Given this list of marker genes WARS1, POP7, PLK4, RNF150, RHOC, PLB1, ZNF618, PLP1, SAGE1, PXDNL, SRL, RHBDF2, PLD1, PRKX, WDR33, RAB9A, SUMO4, CARD19, PSMG2, RUSC1, GFUS, SEPHS2, STARD3, YAP1, PSMA6, SSB, RHOU, RENBP, TTTY13, ZNRF2, SEC61B, PNN, PIGV, PLIN4, TINF2, TIMP1, ROCK1, TRIM36, SLC4A9, TOP1, PLEKHJ1, SNAI3, PSRC1, TRIP6, SLC35F3, SLFNL1, SCARF2, TP53INP2, TNFSF12, SPATC1, PRKAR2B, TINCR, TRIP12, PKN3 (protein kinase N3), TDRD7, SMAD1, UGT2B17, SLC25A3, RPL26L1, SNAP91, TMEM158, TRIM16, SPACA7, THBD, TTC33, PLA2G2A, SMC1A, SCNN1G, SYT14, WDHD1, PSKH2, SOX2-OT, S1PR2 (sphingosine-1-phosphate receptor 2), TRAPPC6B, SLC16A4, PTPN18, ZBED6, RNF10, TMBIM1, TYK2, UBR5, RPS6KB2, ZFC3H1, TRIM55, SLC24A5, PPP2CA, PTH2R, VPS35, TRIM2, ZNF142, TMEM126A, VENTXP1 (NCBI Gene Id 139538), SLC22A18, VCPIP1, RBPMS, SEPSECS, PKD2L1, UTS2B, RSPH3, SEC24D, SLC41A1, PPP4R2, EMC2, WIF1, SAP30BP, TBC1D4, TP53I13, STK36, PCGF6, ROPN1B, POLR2F, SLC9A8, TRIML1, PRAM1, TIMM17A, TMEM63B, TMEM208, UBL7, RTP1, POLR3F, SLC43A3, RAB2B, PDCD5, PML, SNX3, YIPF2, PLCB2, TTC7A, SUSD1, PTPN23, PYHIN1, UTP11, TIPRL, EMC4 (NCBI Gene Id 51234), PDE1A, STK32A, XAF1, U2AF1, PCDHGA8, SAMSN1, ZMIZ2, PRDX3, UBL3, UBFD1, ZNF414, PDE1C, ZCCHC9, ZPBP2, RPE65, UBA3, PF4, SEMA4A, RPS3A (NCBI Gene Id 6189), PYGL, PNPT1, RNF19A, APOL6, RASD1, PDLIM2, TEX12, STXBP5L, ZAN, SLC43A2, UBE2J1, TMEM139, STK25, PEAR1, SNAI2, SOX11, S100P, PDE6G, RSPH10B2, TPMT, PRDX4, PLAAT3, TBC1D1, PRG3, REM2, NECTIN4, TEX11, RNF214, RASA1, PHLDA1, CCN6, PSEN1, ROBO2, SEPTIN3, SLC9A6, UNC13D (NCBI Gene Id 201294), PRDM1, TK1, PPP1R16A, ST7-AS1, TRPM6, UBE2U, PSPN, TOR1AIP1, SERPINA9, TTL, here is a description of the gene set: Human Gene Set: GSE15659_RESTING_TREG_VS_NONSUPPRESSIVE_TCELL_DN Gene expression profiles of subsets of CD4+ T cells according to their expression of FoxP3 and CD45RA were compared. FoxP3 is a key transcription factor for the development and function of natural CD4+ regulatory T cells (Tregs). Here we show that human FoxP3+CD4+ T cells are composed of three phenotypically and functionally distinct subpopulations: CD45RA+FoxP3low resting Tregs (rTregs) and CD45RA-FoxP3high activated Tregs (aTregs), both of which are suppressive in vitro, and cytokine-secreting CD45RA-FoxP3low non-suppressive T cells. The proportion of the three subpopulations characteristically altered in cord blood, aged individuals, and patients with immunological diseases. Terminally differentiated aTregs rapidly die while rTregs proliferate and convert into aTregs in vitro and in vivo as shown by the transfer of rTregs into NOD-scid-common gamma-chain-knockout mice and by TCR sequence-based T cell clonotype tracing in peripheral blood of normal individuals. Taken together, the dissection of FoxP3+ cells into subsets enables one to analyze Treg differentiation dynamics and interactions in normal and disease states, and to control immune responses through manipulating particular FoxP3+ subpopulations. studied in species Homo sapiens Genes down-regulated in comparison of resting regulatory T cell (Treg) versus non-suppressive T cells. from publication Miyara M, Yoshioka Y, Kitoh A, Shima T, Wing K, Niwa A, Parizot C, Taflin C, Heike T, Valeyre D, Mathian A, Nakahata T, Yamaguchi T, Nomura T, Ono M, Amoura Z, Gorochov G, Sakaguchi S (PMID 19464196)